The following is a description of a gene set: Human Gene Set: MIR4503 from publication Chen Y, Wang X (PMID 31504780) species: Homo sapiens Genes predicted to be targets of miRBase v22 microRNA hsa-miR-4503 in miRDB v6.0 with MirTarget v4 prediction scores > 80 (high confidence targets)., and this is the list of marker genes: VMA21, USP13, CELF4, ITPR2, GARRE1, CCDC88A, MDM4, COL1A2 (collagen type I alpha 2 chain), OSBP2, HAUS2, MYO1D, TM7SF3, MSRB3, SLC2A2, USP6NL, PDYN, TSHZ3, ACER3, MAP4K3, PHLDA1 (pleckstrin homology like domain family A member 1), CEP104, TFAP2B, MAP4, ETV1, SC5D, F13B, KHDRBS3, FAM20B, SELENOT, ZFHX4, PCOLCE2, ZBTB21, FNIP2, PIP4P2, TLCD4 (TLC domain containing 4), FERMT2, SLC17A5, HELZ, CCNE2, APOL6, CADM2 (cell adhesion molecule 2), MIS18A, UGT2A1, ZNF445, TBXAS1, FSCB, ANKRD12, SNX1, ZDHHC23, AHR, COMMD8, CUL4B, SLC9B2, NAA30, DNAJA1, NTRK2, CA1, OTC, CTSV, SLC30A7, PAG1, GPR34, DCTN4, MAL2, DCX, SMAD5, VPS13C, PPP1R21, CTAGE1, DKK1, C9orf153, TFG, TMEM33, FASLG, PLGLB2, KHDRBS1, IDE, TMEM255A, KCNE4, XPO4, CELF2, STBD1, PUS7, SLC16A10, STX16, MN1, MORF4L1, MBNL1, ELAVL2, ZCCHC17, SELENOF, GPR6, ASPH, GSDMA, SLC30A10, ZNF195, FCGR2A, CTNNB1, SIMC1, WDR7, LY75-CD302, TNKS2 (tankyrase 2), TMEM38B, C9orf72, FMR1, CDK13, DYRK1A, PAPPA, SPATA22, CCND2, PIK3C3, GREM1, SLC4A8, NUDT11, CFAP20DC, TMBIM4, CLTB, FAM135A, BACE2, ANKRD62, SETD2, GDAP2, EFR3A, MAP4K5, NAP1L4, RANBP9, LMNB1, RWDD4, KANSL1, FAM177A1, NXT2, SUZ12, TENT5A, NEXMIF, NCAM1, NCOA3, HMGCR, PCK1, PIGG, MS4A7, TOR1AIP2, VEZF1, RANBP2, FOXP2, PIGBOS1, SMAP2, PTCH1, BLOC1S6, STXBP5, GPR137C, CAPS2, RABGAP1, CNPY1, CNTRL, BCL11B, TSPYL1, ARFIP1, SH2D1B, MIA2, RAB36, WLS, SYVN1, LIAS, TBL1XR1, SESN3, ING2, ALAS1, DIXDC1, SVIP (NCBI Gene Id 258010), MTDH, STAG2, BICRAL, FAM120A, MED13, C14orf39, DOCK11, RNF180, SPRY1, ZNF827, PNMA8A, TPD52, STYX, PTPRN2, MYT1L, ZDHHC2, SLC6A4, LAMP5, C8orf34, UGT2A2, EAF1, CDV3, TMEM104, PITPNA, WDR26 (WD repeat domain 26), DOCK5, GTPBP10, FBXL3, TMEM135, GNGT1, TMEM30A, SLC25A27, AFF1, VPS37A, DCAF8L1, PLGLB1, HIVEP3, WASHC2C, ERICH2, RUFY2, RAP1A, PRKAA2, NAP1L1, RAP1GAP2, MARK1, BPTF, GRIN2A, FGF13, HS3ST5, ZNF664, CPEB2, PREX2, SPAST, LACTB, IRS1, MCC (NCBI Gene Id 4163), TSHZ2, CD302, MID1, RNF11, PLS1, PACSIN2, ROBO2, SREK1 (NCBI Gene Id 57833), CPSF6, MEGF10, C15orf61, PBLD, KCNC2, SEC24B, SERTAD4, ZNF689, IFNA16, SMCHD1, RAB14, CBLN4, GNB4, SCN2A (sodium voltage-gated channel alpha subunit 2), FKTN, INSM1, DCTN5, RAB39B, RAB18, ERCC6, PXK, PCGF3, YTHDF3, CAV2, TBX5, RAB8B, RELN, PABPC4L, MASTL, LRRC51 (NCBI Gene Id 120356739), ENTPD1, KIAA0319, CTTNBP2NL, FKBP5, DCLK1, TNPO1, KMT2C, AQR, PRTG, RRAGA, SPART, KLHL31, PLPP3, GPRIN3, COL9A1, DENND4C, TNMD, LIMS1